Given this list of marker genes Tsr1 (NCBI Gene Id 216950), Utp25, Xrcc5, Bms1, Isg20, Nhp2, Tbl3 (transducin (beta)-like 3), Prkdc, Rrp9, Dhx37, here is a description of the gene set: studied in species Mus musculus Binding to a U3 small nucleolar RNA. Mouse Gene Set: GOMF_U3_SNORNA_BINDING